Given this list of marker genes CTNNB1, PSMB7, PSMC4, MSGN1, PSMD6, PSMD11, PSMC2, PSMB3, PSMD14, PSMC1, SEM1, PSMD12, ADRM1, PSMA6, MESP2, PSMA1, TBX6, PSMB1, PSMB4, PSMC6, PSMD13, DLL3, PSMB6 (proteasome 20S subunit beta 6), PSMA2, PSMB5, PSMA5, PSMD3, PSMA4, RBPJ, EPHA4, PSMD2, PSMA7, PSMB2, PSMD1, LEF1, PSMC5, NOTCH1, PSMD8, PSMD7, PSMA3, PSMC3, HES7, LFNG, RIPPLY2, DLL1 (NCBI Gene Id 28514), here is a description of the gene set: species: Homo sapiens Human Gene Set: REACTOME_SOMITOGENESIS Somitogenesis